The following is a description of a gene set: Mouse Gene Set: GOBP_NEGATIVE_REGULATION_OF_VOLTAGE_GATED_CALCIUM_CHANNEL_ACTIVITY Any process that stops, prevents or reduces the frequency, rate or extent of voltage-gated calcium channel activity. species: Mus musculus, and this is the list of marker genes: Drd4, Calm1, Dysf, Cbarp, Gnb5, Gpr35, Calm3, Drd2, Cacna1f, Fmr1